Given this list of marker genes ACE, CXCR5, KLHDC8A, TTLL8, TEKT4, MPP3, OR2Z1, LECT2, CLEC14A (C-type lectin domain containing 14A), REG3G, MMP15, LSS, SLC4A1, MSI1, WDR97, AIFM3 (AIF family member 3), RNF215, PAX4, FGF22, FTLP4, ANGPTL4, ZNF467, SIGLEC8, HSP90AB4P, SEMA6B, TNFAIP2 (TNF alpha induced protein 2, NCBI Gene Id 7127), NEU2, SPINT3, DNAJB8, IZUMO1R, ADCYAP1R1, CYP4F8, ITGB2, UBQLNL, MUC16, EPHX2 (NCBI Gene Id 2053), SOWAHD, BTG2, KCNT1, PLA2G2E, BARHL2, ISLR, DEFB134, KLHL17, TMEM130, RTP2, PHF21B, NKX2-6, IRF1, LCE1A, KRT9, CABP4, SERTAD4, OTOG, C17orf99, FZD10, ART5, PTGES, EMX1, ATP1A3, SLITRK5, PRKAG3, CHI3L1, EEF1A2, CTAG2, RHBDF2, LILRB5, GSTM5, PLAAT4, CCL11, LINGO4, SCARA5, KCTD4, TNFSF14, RTP4, ADRA2A, PLXNB2 (NCBI Gene Id 23654), OPLAH, CD207, SSTR1, CCL13, F7, PRSS37, KRT15, ASPG, KRT18P17, PPIL2, CAMK2A, KCTD17, CEACAM4, CDK20, ASCL4, OR8U1, VEGFB, BRSK2, COL1A1, GOLT1A, RHO, NFATC1, ZNRF4, ACTL7B, CD79B, CXCL3, MRGPRX1, ARHGEF10L, CD52, OR8S1, PARD6A, RAPSN, GNGT1, HMCN2, PRR5, PNMA5, LCE5A, JAG2, INHBB, APLP1, AMER3, PPP1R26, SPMIP9, PGD, PXDN, GNPTG (N-acetylglucosamine-1-phosphate transferase subunit gamma), AGO1, ZFHX2, TRH, SYT8, IHH, TIMP4, CPZ, SLC45A4, TSKU, HPCAL1, GEM, SLC6A12, CCL20, DMKN, PRSS29P, MNX1, ESS2, SOX8, LIF, CIBAR2, PCK1, TLX1, LILRB4, GPR182, TRIM29, GJB4, DUSP23, UBQLN3, KRT18P38, OBP2B, FRMD1, CHST15, CARINH, GRB7, CLDN14, KRTAP4-4, TMIE, C1QL1, TNNI2, PLIN5, TRPV4, UNC5A, NT5C1A, OXER1, TMEM252, COX4I2, CSHL1, HAND1, NANOS3, TACSTD2, KRTAP5-10, ZDHHC22, MAPK15, TAS2R1, PLCB2, GFRA4, LINC00319, C14orf180, KRT34, MN1, ATP1B2, PAXX (PAXX non-homologous end joining factor), VANGL2, CST9, ATP6V0E2, GFPT2, KCNK15 (potassium two pore domain channel subfamily K member 15), PHETA1 (PH domain containing endocytic trafficking adaptor 1), IGSF21, KLK7, PLCH2, HS3ST6, HIC1, ICAM1, CD14, RPL13AP3, NKX2-2, LINC00469 (NCBI Gene Id 283982), VAX1, TLDC2, PARP2, EEF1A1P32, BPIFB6, CRYBA2, MSLN, CACNA1H, IL10RA, TNFRSF14, AQP9, DEFA6, ASB10, VAV2, CDH23, AJAP1, IL32, TPSG1, MAG, ZMYND15, SHISA3, CELF4, ARID3C, ALDH3B2 (aldehyde dehydrogenase 3 family member B2), TFF2, SHB, CSF1, SST, ELF3, APOC1, ERFE, CCL22, SLC22A12, PCDH1, AGXT, NHLRC1, SEPTIN4, EFNA2, ZG16B (NCBI Gene Id 124220), SLC13A5, OR51G1, CYP26C1, RIPK3, CNTN2, WNK2, GPR35, AQP10, SLC6A18, PNOC, CYP11B1, SLITRK1, VSX2, SPEM2 (NCBI Gene Id 201243), IL13, PAX5, LINC01559 (NCBI Gene Id 283422), CCN4, TMEM171, NEFM (neurofilament medium chain), FAM241B, LRRC15, CFAP126, MUC5B, FOXI2, ANKRD33, KIF2B, CDKN1C, TMPRSS2, PRDM16, S100A14, REG4, LRRTM4, ID1, FOXN1, SNCB, CABP7, CMA1, METTL27, TMSB10, DHRS2, FAM131C, SMG6, CD1C, PLA2G2D (NCBI Gene Id 26279), FSCN3, DCAF4L2, TKTL2, C9orf152, IL2RB, MGAT5B, UNC93A, SLC6A17, GBA2 (NCBI Gene Id 57704), PTH1R, KRT38, SLC6A20, SLC52A1, DPEP1, MMEL1, KCNJ4, KLK3, SPATC1, TNNT3, RXFP3 (NCBI Gene Id 51289), C1orf210, LINC00029, SCIMP, KRT71, CLDN3, FCER2, PTPRF, CBARP, MRPL36, LINC02692 (NCBI Gene Id 203235), NCF1, CEP131, LAMB3, CTSD, CCM2L, DMRTB1, IRX6, CYP2D6, HOXC9, KRT37, BMP2KL, KRT36, DPYSL4 (dihydropyrimidinase like 4), PGLYRP3, PAK4, TMEM59L, ARTN, HSPA2, PLSCR3, FAM83C, SBK2 (SH3 domain binding kinase family member 2), PCDHB18P (protocadherin beta 18 pseudogene), CDH24, COL5A1, TNNT1, MYOD1, RPTN (repetin), SYT7, GRM6 (glutamate metabotropic receptor 6), CELSR2, SEMA6C, ICAM4, TMEM256, FZD9, FEZF2, OPTC (NCBI Gene Id 26254), AVPR2, AZGP1P1, DACT2, RASSF7, PRR9, CRYBG2, PRAMEF12, KCNC4, PLA2G2A (phospholipase A2 group IIA), CD248, UNC119, IRX4, MXD4, CA4, EN2, NGB, CDK5R2, MLXIPL, MINDY4, GARIN1A, SLC25A5P6, LMX1B, XIRP1, NAPRT, NKX2-5, LDHAL6B, TMEM63C, GPR6, SIM2, COL6A1, SOX21, C16orf90, C3orf18, F2RL3, AKT2, CEACAM20, CAMK2N1, TMC8, GCNT2P1, PTP4A3, FBXO2, ATP4A, KRT79, SCN1B, KCNA10, GAL3ST1, KLHL40, ACTL7A, RND1, MAGEH1, DRD2, GDF15, PTGER2, NDUFS7, NAPSB, CIMIP2B, SPACA3, DKK4, PKDREJ, C16orf92, CMTM2, DISP3, NMUR1, OR1G1, MYO7A, S100A9, HMGB4, WSCD1, IFI27L2 (interferon alpha inducible protein 27 like 2), GPR12, FOXI1, CACNG1, TREM2, B3GNT8, CA9, MAFB, SLC22A18, SIGLEC15 (NCBI Gene Id 284266), RARRES2, OR9G1, SLC32A1, NLRP6, ALDH1B1, KIF5A, IRX2-DT, IGLON5, SERPINC1, KRT19, RSPH14 (radial spoke head 14 homolog), CEACAM3, MIER2, PADI4, SLC7A4, ZNF835, OTOS, FXYD4, RAX, CBLN1, NKX6-1, SLC26A10P, MC5R, WFDC10A, HTR1B, OTOP2 (otopetrin 2), EPHA2, RAMP2, KCNA5, USP5, NEURL3, LINC00482, SLC4A3, LCN8, KRT72, SERPINA5, WNT7B, DTX3, PRSS46P, CCDC8, BPI, WDR25, HTR3A, KRT2, TMEM81, FAM187B, DENND6B, CYP26B1, MS4A10, HOOK2, OR8U8, SPON2, TG, KLK10, EFS, GH1 (growth hormone 1), SLC34A1, EMC10, SCUBE1, PTGS1, ZC3H3, NEUROG3, KLK2, CDK18, SPATA20, MAPK11 (NCBI Gene Id 5600), RNF186, ZNF34, ADAM33, LGI4, CD164L2, C1QTNF8, GRIN3B, EMILIN3, LFNG, TMPRSS3, KRT74, LINC00304, CALML3, UCN (urocortin), MUC4, DHRS3, TFF1, GH2, CD22, CAMK1G (calcium/calmodulin dependent protein kinase IG), HHATL, GPHA2, SHANK2, TMEM74, PROK1, KLK8, SLC25A34, ENO2, MIP, IRX2, KCNA6, CIMIP1, OR6S1, TNNI3 (NCBI Gene Id 7137), KLHL22, KLK1, FOXD1, G0S2, TCL6, ADAMTS8, GSX2, GARIN6, IGFBP3 (insulin like growth factor binding protein 3), LRFN3, PLA2G3, PTGER1, TMEM174, PIAS3, APOL1, PGLYRP2, SPATA8, FSD1, FGR, HTR1A, CILP, LRATD2, ARSI, AGT, FAM20C, CHRNB4, OLFM1, KLKP1, ITIH3 (NCBI Gene Id 3699), MPEG1 (macrophage expressed 1), SCARF1, PANX2, TMEM179, PPIC, CRIP2, OR9G9, FBP1, OR2B11, KCNE5, GJA5, FMOD, NHERF4, AIPL1, SERPINA9, PIK3R5, CEACAM8, NEUROG2, ZBTB47, LHFPL7, SUN5, MLNR, TXNDC2, FAM50B, HEPACAM, FGFR4, LEP, PTPRU, TMEM61, PCSK4, CLPS, PLPP7, SH2D5, GNA11, PAX7, CHAC1, COL20A1, MMP11, SUCNR1, SUSD2, KLK6, CRABP1 (cellular retinoic acid binding protein 1), CHRNA4, LILRA5, SH3BP4, ZNF749, ELFN2, PRRT1, TMEM151A, MUC2, GZMH (NCBI Gene Id 90562), TRIM46, OR2C3, OR51H1, AGAP2, FXYD5, LRRC26 (NCBI Gene Id 414321), MUC6, PGAP6, ABCD1P2, CD93, KRT83, BCAM, BCAN, TMEM184B, EGR3, CD300A, DBH, DCSTAMP, POU4F3, TMEM92, LYPD2, KCNK9, KCNC1, SERPINA10, TRAM1L1, LMO1, COL16A1, HCN4, EPS8L2, AQP6, SLC16A8, EMX2, FLT4, CD79A, CCL24, ECHDC3, SLC25A47, SNORC, FAM181A, GLRXP3, FGF17, RRAD, PRAM1, OR10V1, MYL7, B4GALNT4, INS, CARD14, PLK2, CXCR1, CYP2S1, KIF1A, ADAMTS2, LAMC3, IL1F10, NOTCH3, GPR25 (G protein-coupled receptor 25), GRIN1, KNDC1, CCDC185, ODF1, SCN2B, CXCL14, ASIC4, IFNL2, C2CD4C, OR8U9, WNT11, DMRTA2 (NCBI Gene Id 63950), S100A6, CLCNKA, IRX1 (iroquois homeobox 1), CEP170B, KRTAP16-1, REP15, ANKK1, TLX2, DRD5, HRAS, NKG7, PRIMA1, REEP2, CD5, SMOX, WTIP, PTK6, LRRN2 (leucine rich repeat neuronal 2), KLK12, ANGPTL7, AIRE, STRA6, EIF4E1B, ALOX5AP, KCTD11, CST5, PCDHA7, SLC12A7, CCL2, MYOM3, PCSK9, TP53TG5, RASSF10, ACKR1, SIX6, AOC3, MYL3, PRRX2, C1QA, SLC4A9, ASB2, C19orf67, CAPN9, CHST8, PLET1, LPIN3, NPTX1, FUT6, IVL, SMTNL2, TNFRSF1B, NRBP2, LRG1, SPRR4, CABP2, AXIN2, GPRIN2, PCDHA1, TOGARAM2 (TOG array regulator of axonemal microtubules 2), PHYHIP, GZMM, ZIC4, HOXB3, ALAS1, OR6F1, S100A8, PCSK1N, BARX1, DOK7, KRT85, NKX3-2, GDF2, IGFBPL1, VSIR, FGF4, MYBPC3, DEPP1, IGSF9, SLC6A7, RAET1G, SSTR3, ZNF439, SLC6A3, CACNA1I, CCR1, MT3, CYP2A7P1, MFNG, C1QB, ZNF859P, MCEMP1, CAMKK1, PCDH8, PROM2, APOL4 (apolipoprotein L4), MYBPH, MYMK, ACVRL1, KRT8P26, OTOP3, BATF2, HRH3, CYP4B1, HOXC13, ARHGEF15, CSF2RB, ELOA2, CHI3L2, UBE2O, BIRC7, DEFA4, PRSS50 (serine protease 50), HK3, KRT35, FGF8, FOXA2, SLC26A11, ELOF1, RBBP8NL, GNAQP1, CD300LG, PDCD1, IFT27, KRT18P49, SLC6A19, ZSCAN1 (zinc finger and SCAN domain containing 1), ADRB3 (NCBI Gene Id 94406), TTLL4, DPEP3, PLK5, MT1CP, GARIN5B, COX7A1, TREML4, TGM2, NUPR1, PRSS33, LY6H, CAVIN3, OPN4, KIRREL2, HSPB7, PIP5K1C, NKX6-3, GPR101, SERPINA1, SPDYC, SLC2A5, GGT6, PDLIM4, GPX3 (glutathione peroxidase 3), TMEM132E-DT, TUB, CRYBB3, ADRA2C, MFSD6L, MT1G, WDR5B, ITPRIPL1, MRGPRX4, FOXQ1, B3GNT6, THAP8, TMEM213, BDKRB2, RTP3, CALML6, OR2W6P, HGFAC, C4orf50, EPHA8, SCN5A, CTXN3, GPR31, KCNE4, GRM2, here is a description of the gene set: species: Homo sapiens Many different molecular mechanisms have been associated with PML-RARalpha-dependent transformation of hematopoietic progenitors. Here, we identified high confidence PML-RARalpha binding sites in an acute promyelocytic leukemia (APL) cell line and in two APL primary blasts. We found colocalization of PML-RARalpha with RXR to the vast majority of these binding regions. Genome-wide epigenetic studies revealed that treatment with pharmacological doses of all-trans retinoic acid induces changes in H3 acetylation, but not H3K27me3, H3K9me3, or DNA methylation at the PML-RARalpha/RXR binding sites or at nearby target genes. Our results suggest that PML-RARalpha/RXR functions as a local chromatin modulator and that specific recruitment of histone deacetylase activities to genes important for hematopoietic differentiation, RAR signaling, and epigenetic control is crucial to its transforming potential. from publication Martens JH, Brinkman AB, Simmer F, Francoijs KJ, Nebbioso A, Ferrara F, Altucci L, Stunnenberg HG (PMID 20159609) Human Gene Set: MARTENS_TRETINOIN_RESPONSE_UP Genes up-regulated in NB4 cells (acute promyelocytic leukemia, APL) in response to tretinoin; based on Chip-seq data.